The following is a description of a gene set: species: Homo sapiens Human Gene Set: MIR7977 from publication Chen Y, Wang X (PMID 31504780) Genes predicted to be targets of miRBase v22 microRNA hsa-miR-7977 in miRDB v6.0 with MirTarget v4 prediction scores > 80 (high confidence targets)., and this is the list of marker genes: PLEKHH2, PHF1, BSDC1, IGDCC4, GNG2, KIT (KIT proto-oncogene, receptor tyrosine kinase), C15orf40 (chromosome 15 open reading frame 40), FERRY3, ACACB, CLASP1, UBE2R2, SMIM12, PTPRO, ACBD4, DNAJB12, OPRK1, ATXN1L, GRAMD1B, PRR13, BRSK2, SDCBP, ZFP2 (NCBI Gene Id 80108), TFDP2, ZDHHC11, TXLNA, MICAL2, WDR55, MPZL2, SYT11, IL6R, RFFL, ZNF703, GLS (NCBI Gene Id 51679), PLXND1, ZMYND8, KIF3C, PCP4L1, TUB, GUCY1A2, SDF2 (NCBI Gene Id 6388), SEMA4C, POU2F3, RXRA, MDM2, PARPBP, CCDC110, SP1, TOM1L2 (NCBI Gene Id 246315), ZNF467, RTF2, NCAPG2, ARMH3, SUSD6, MAVS, ZNF805, ORAI2, CLCN4, ATG9A, IRGQ, SDC2, SP4, SGTB, ZFYVE27, MICOS10, SH3TC2, ZBTB3, STRADB, IKZF3, HP1BP3 (heterochromatin protein 1 binding protein 3), IRAK1BP1, ZDHHC18, MAP2, CADM1, SMUG1, ZNF557, LRRC51, ATP2B2, PTGFR, PCBP1, ZFYVE21, TSPAN5, VASN, JPH1, PLAG1, ZNF546, PLEKHG4B, ELAPOR1, APOL6, PPP4R2, SLC2A10, TTC4, SENP5, LEPROT, APOBEC3F, ADRA1D, DCLK1, CTPS1 (CTP synthase 1), PLEKHH1, DAP, CHCHD4, ACBD3, UTP15, ING5, KIAA0930, PROX1, PTPN12, PEX5, SKA2, IFNLR1, FAM234B (family with sequence similarity 234 member B), ENTPD7, CRP, MCOLN3, CPXM2, WDR33, PLA2G6, UNC45A, FAM20B, GNGT2, C3orf70, ARHGEF37, SEC22C, KLK3, SOX3, CLINT1, IFT140, SRFBP1, OLA1, DCAF17, MPRIP, ZSCAN18, STK4, NT5DC3, RAB5C, PPP1R16B, CSNK1D, HNF4A, MTPAP, POU2AF1, KCNE4, CD2AP, ST3GAL1 (ST3 beta-galactoside alpha-2,3-sialyltransferase 1), CMKLR1, MAP3K13, RNF135, CD80, EPHB2, CRY2 (cryptochrome circadian regulator 2), GOLGA2, VWA5B2, NBPF12, ANGEL1, CASTOR2, JADE1, VAMP3, ZNF490, NSUN2, HEPN1, RFX2, IQCG, BST1, RAD51D, NFIB, KDR, CEP170B, HMGA2, VPS26B, LTBP2, ZNF582, RABGAP1L, C2 (NCBI Gene Id 12263), SAA2, FOXK1, SLC38A3, LMAN2L, EFCAB14, ABL2, SLC48A1, IGF2BP1, TMEM169, PRR5L, NRP1 (NCBI Gene Id 8829), TYRP1, PLXNA2, WNT9B, MAPKAPK3, CASQ2, SH3BP5, SFMBT2, RASSF2, NDST1, MTHFR, PANK2, TOX4, LATS1, ZNF568, ISL2, FIGN, KCNH8, MTMR14, XYLT1, CSRNP3, SAXO2, S100A14, DNAJC30 (DnaJ heat shock protein family (Hsp40) member C30), IRAG2, PLCXD1, SELENOK, MTCL2, SLC35E2A, KCNC4, MRPS12, ADCYAP1R1, BNIPL, RUNDC3B, ZNF554 (NCBI Gene Id 115196), CLMN, DPY19L1, CEP15, DENND6A, ZNF587, PSD3, RUNX1T1 (RUNX1 partner transcriptional co-repressor 1), SLC44A1, KLHL6